Given this list of marker genes ALDOA, PYGM, RYR1, LDHA, CACNA1S, ACADVL (acyl-CoA dehydrogenase very long chain), here is a description of the gene set: Exercise-induced rhabdomyolysis Rhabdomyolysis induced by exercise. Human Gene Set: HP_EXERCISE_INDUCED_RHABDOMYOLYSIS studied in species Homo sapiens